The following is a description of a gene set: This event has been computationally inferred from an event that has been demonstrated in another species.<p>The inference is based on the homology mapping from PANTHER. Briefly, reactions for which all involved PhysicalEntities (in input, output and catalyst) have a mapped orthologue/paralogue (for complexes at least 75% of components must have a mapping) are inferred to the other species. studied in species Mus musculus electronically inferred by orthology from the curated human pathway part of: TCR signaling Reactome Pathway: Downstream TCR signaling, and this is the list of marker genes: Psma7, Ikbkb, Psmd6, Psma2, Nfkb1, Tab2, Psmd7, Ube2n, Malt1, Psma4, Psma1, Pik3r2, Psmb4, Psma5, Psma6, Ubb, Psmc3, Psmb5, Nfkbia, Psmc1, Psmd13, Psmd12, Cd3e, Psmc5, Ube2v1, Cul1, Psmc4 (NCBI Gene Id 23996), Psmb7, Psmc2, Cd3d (CD3 antigen, delta polypeptide), Rps27a, Ube2d1, Cdc34, Psmd1, Psmc6, Trat1, Cd3g, Pdpk1, Lck, Psmb6, Psma3 (proteasome subunit alpha 3), Rela, Pik3cb